The following is a description of a gene set: species: Homo sapiens Genes up-regulated in comparison of eosinophils versus Th1 cells. from publication Jeffrey KL, Brummer T, Rolph MS, Liu SM, Callejas NA, Grumont RJ, Gillieron C, Mackay F, Grey S, Camps M, Rommel C, Gerondakis SD, Mackay CR (PMID 16474395) In the present study we used Affymetrix oligonucleotide microarrays to produce gene transcription profiles for the major leukocyte types in humans. This comprehensive dataset enabled us to not only establish which genes were expressed in each leukocyte type, but also which genes were expressed in each subset after activation. The used of a comprehensive dataset of gene profiles from all the major human leukocyte subsets enabled a novel and powerful means for identification of genes associated with single leukocyte subsets, or different immune paradigms. Human Gene Set: GSE3982_EOSINOPHIL_VS_TH1_UP, and this is the list of marker genes: PPP2R3A (protein phosphatase 2 regulatory subunit B''alpha), THBS4, IDO1, EEIG1, PRKAR2A, SPATA1, TNFAIP6, IKZF5, SLC16A10, MAEA, HIF3A, LPIN1, SH3BGRL, TMEM9B, MAP3K5, IGF2-AS, USP19, AP3S1, FBP2, PHF20, NMT2, NR1D2, DMTF1, EIF4G2, KDM6A, ROGDI, DENND5A (DENN domain containing 5A), SPINT2, UNKL, BOK, ANXA1, REG1B, RAB33B, PGS1, CYLC2, OSBPL8, HECA, MON2, PRDM5, SLC17A1, ADAM8, S100P, VCL, ARHGAP25 (NCBI Gene Id 9938), PRSS21, DLGAP1, ZNF721, KIF5A, VGLL1 (vestigial like family member 1), CHIA, SOCS7, RABGEF1, MIR9-1HG, HIPK1, ITIH4, CKAP4, F7, VPS37A, GLYAT, TBC1D5, HOXB1, OSBPL2, MGAM, BTBD7, H3C12, SERINC1, TLR4, ZNF432, KIT, ERBIN, GRIA2, IPO13, FCAR, NFE2L2, CD44, VN1R1, CYRIA, HLA-C, TRPC4AP, SSPN, KRT2, CTDSP2, ZDHHC17, MMP2, HARS2, IL6R (interleukin 6 receptor), PTPN22, CASQ1, PTPRE, NHLRC2 (NCBI Gene Id 54835), NME4, NFE2, XRCC2, FCGR2C, PPM1B, CPN1, ESRP2, GPR12, LIMK2, RGL2, FGF7, CD9, NSUN6, SPATA6, WIPI1 (WD repeat domain, phosphoinositide interacting 1), B3GAT1, GABRR1, LAPTM4A, DBT, LMOD1, MTMR3, CEBPE, HCP5, CD244, PDLIM2, TRPC6, ANKRD55, UBA3, TET3, BAZ2B, HLCS, TREH, C1orf115, PRNP, IL25, SLC22A18AS, SLC25A42, LY75, SLN, SLC26A1, ZNF14, PNRC2, PTPN12, LRRFIP1, PIK3CB, DPP8, FGR, TGFB2, GAS7, NKTR, APCS (NCBI Gene Id 325), MARCHF3, SRPK1, GRM4, NXN, SPI1 (NCBI Gene Id 6688), MEIS2, CCL23, NOL10, IFNAR2, CLOCK, SCRG1, SUMO1 (small ubiquitin like modifier 1), BMX, CHST15, SEC62, INSR, RNF11, TLE3, ZNF217, CD164, HNRNPA3P1, SUPT20H, LOXL2, PTAFR, UBE2E3, CHP1, MOAP1, INPP5B (inositol polyphosphate-5-phosphatase B), SMPD3, ATF1, NADK, TSR2, NOTCH2, NHLH2, LILRA2, PITPNM3, ADPGK (ADP dependent glucokinase), ITFG2, DUS2, RAB3GAP1, CACNA1S, PLEKHF2, RHEB, PLAC8, LIN37, RNF144A, TAS2R14, MARCHF7, MAN2B2, CLK1, CTRL, KLHL4, CMTM6, CD55